The following is a description of a gene set: Regulation of mitotic cell cycle currently covers APC/C-mediated degradation of cell cycle proteins. Reactome Pathway: Regulation of mitotic cell cycle part of: Cell Cycle, Mitotic studied in species Homo sapiens, and this is the list of marker genes: ANAPC7, PSMB7, BTRC, CDC23, PSMB3, UBC, CCNA2, PSMD14, ANAPC10, PSMB5, PSMC4, PSMA4, PSMB4, SEM1, ANAPC5, SKP2, PLK1, BUB3, PSMD13, CDC27, PSMD1, UBB, CDC14A, PSMD2, RB1, PTTG1, PSMD3, FBXO5, PSMD7, PSMB6, UBE2E1, PSMD8, PSMD6, ANAPC1, PSMC2, UBA52, ANAPC2, PSMC6, CDC16, CDK2, MAD2L1, ANAPC15, AURKB, CDC20, BUB1B, PSMA6 (NCBI Gene Id 87553), PSMA2, SKP1, PSMC5, ANAPC4, CCNA1 (NCBI Gene Id 8900), UBE2C, CDC26, CCNB1, FZR1, PSMD12, PSMC3, PSMA5, UBE2S, CUL1, ANAPC16, PSMB1, UBE2D1, PSMB2, PSMA1, CDK1, RPS27A, PSMC1, PSMD11, ANAPC11, AURKA, NEK2, PSMA3, ADRM1, PSMA7